Given this list of marker genes HECTD1, UBE4A, ANAPC13, UBR2, FBXO27, RNF220, PSMB3, FBXW8, CDC34, UBR1, FBXO40, PSMD1 (NCBI Gene Id 5707), DET1, KEAP1, ASB14, PSMD14, TRIM39, UBE2V2, RNF25, UBE2G2, FBXO32, ASB4, UBE2B, UBR4, ANAPC11, DCAF1, TRIM21, ASB8, THOP1, SPSB2, UBA6, UBE2D3, FBXO10, FBXO21, UBE2A, UBE2S, PSMC1, RNF126, PSMC2, FBXW9, TRIP12, WSB1, SEM1, FBXW10, FBXW12, RNF19A, CBLB, FBXW11, PJA2, UBAC1, LNPEP, BLMH, RCHY1, WWP1, ASB16, TRIM41, PSMD2, TRIM69, RNF34, HECW2, PSMB4, UBE2E1, CUL3, UBE2C, SOCS3, ASB3, MGRN1, RNF217, FBXO31, FBXO22, UBE2M, UBA3, ASB18, FBXL15, FBXO15, UBE2G1, CUL1, UBE2K, HUWE1, UBE2D4, HERC6, BTBD6, FBXL20, ZNRF1, TRIM32, KLHL41, HACE1, RBX1, CUL5, CUL2, KLHL22, RNF14, TRIM37, PSMC5, LRR1 (leucine rich repeat protein 1), RNF213, UBE3A, ANAPC10, TRIM50, TRIM36, NEDD4, ASB1, RNF4, MYLIP, RLIM, RNF182, KBTBD6 (NCBI Gene Id 89890), RPS27A, CDC20, FBXL13, RNF7, PSMB1, UBE2V1, UBA5, FBXO11, RBBP6, UBE3D, STUB1, RNF41, FBXL16, KLHL11, UNKL, UBE2F, FBXL4, PSMD13 (NCBI Gene Id 5719), FZR1, UBE2Q2, ASB7, TRIM9, UBE2W, UFL1, LNX1, ASB12, ASB10, DTX3L, KLHL5, FBXL5 (F-box and leucine rich repeat protein 5), KLHL3, TRAF7, FBXL14, ASB11, PSMB7, RNF123, PSMC3, KBTBD13, ANAPC1, KLHL42, ELOC, HECTD2, UBE2O, ANAPC7, UBE2D2, SKP1, FBXO7, RNF114, FBXW5, BTRC, LRSAM1, UBA1, KLHL20, KBTBD7, PSMA1, ANAPC5, UBE2E3, SKP2, KLHL21, PSMB5, DZIP3, FBXL8, KLHL13, RNF144B, KLHL9, RNF138, SPSB4, ATG7, FBXW2, GLMN, TRIM63, PSMC4, UBB, SH3RF1, CDC26, UBE3B, PSMA4, SMURF2, FBXO4, HERC5, HERC1, UBA7, FBXO44, PSMD8 (proteasome 26S subunit, non-ATPase 8), UBC, PSMD6, UBE2L3, BTBD1, AREL1, RBCK1, FBXL3, UBE2Q1, ADRM1, CBLL2, UBE3C, CUL7, PSMA2, ASB13, ASB9, PSMD12, FBXO6, SIAH1, UBE2Z, PSMB6, RNF111, RNF6, TRIM71, HERC2, FBXO41, ARIH2, PSMC6, PSMA6, UBOX5, PSMA5, UBE2U, TPP2, TRIM4, LMO7, FBXL18, TRAIP, SPSB1, SOCS1, FBXW7, FBXW4, KCTD7, FBXO2, FBXO17, ZBTB16, HERC4, ASB17, ASB6, UBE2J2, PSMD7, KCTD6, GAN (NCBI Gene Id 8139), ANAPC4, CDC27, RNF115 (ring finger protein 115), MEX3C, MIB2, ANAPC2, LRRC41, FBXL21P, CDC16, UBE2H, FBXO30, FBXL7, SMURF1, MKRN1 (NCBI Gene Id 392799), LTN1, TRIM11, FBXL22, PSMA3, RNF130, ELOB, KBTBD8, UBE2J1, PJA1, UBE2N, UBE2R2, PSMD11, LONRF1, UBE2E2, ASB5, CCNF, NPEPPS, RNF19B, UBE2D1 (NCBI Gene Id 9335), CDC23, HERC3, PRKN, ASB2, PSMD3, UBA52, FBXL12, KLHL2, ZNRF2, FBXL19, PSMB2 (proteasome 20S subunit beta 2), HECTD3, NEDD4L, ITCH, ASB15, UBE2L6, VHL, SIAH2 (siah E3 ubiquitin protein ligase 2), KLHL25, PSMA7, FBXO9, here is a description of the gene set: part of: Class I MHC mediated antigen processing & presentation studied in species Homo sapiens Reactome Pathway: Antigen processing: Ubiquitination & Proteasome degradation Intracellular foreign or aberrant host proteins are cleaved into peptide fragments of a precise size, such that they can be loaded on to class I MHC molecules and presented externally to cytotoxic T cells. The ubiquitin-26S proteasome system plays a central role in the generation of these class I MHC antigens. <br>Ubiquitination is the mechanism of adding ubiquitin to lysine residues on substrate protein leading to the formation of a polyubiquitinated substrate. This process involves three classes of enzyme, an E1 ubiquitin-activating enzyme, an E2 ubiquitin-conjugating enzyme, and an E3 ubiquitin ligase. Polyubiquitination through lysine-48 (K48) generally targets the substrate protein for proteasomal destruction. The protease responsible for the degradation of K48-polyubiquitinated proteins is the 26S proteasome. This proteasome is a two subunit protein complex composed of the 20S (catalytic core particle) and 19S (regulatory particle) proteasome complexes. The proteasome eliminates most of the foreign and non-functional proteins from the cell by degrading them into short peptides; only a small fraction of the peptides generated are of the correct length to be presented by the MHC class I system. It has been calculated that between 994 and 3122 protein molecules have to be degraded for the formation of a single, stable MHC class I complex at the cell surface, with an average efficiency of 1 in 2000.